Given this list of marker genes MFN2, NPAS2, VEGFD, GEM, CEP104, TOPBP1, MMD, MYL12B, DIXDC1, PGGT1B, PUM1, SNW1, CEP170, NR4A2, RBM19, ATF3 (activating transcription factor 3), SLC35B1, INPP5F, KCTD12, ZNF140, STXBP3, TGIF1, UBAC1, GNG5, PSG1, ACSL1, TNFSF11, ADGRE5, ZNF135, GOLGA8A, SLC31A1, RPS27A, IQCB1, NUP42 (nucleoporin 42), ATRX, AKAP1, IPO7, ADO, PLA2R1, PPT1, RP2, GABARAPL1, FABP5, IL23A, IER2, DDX52, RPS25 (NCBI Gene Id 6230), CENPE, WDHD1, ABCB7, TSC22D2, ADARB1, BTG3, ZEB2, TMEM268, SUSD6, RFTN1, STK25, ACSL4, NFKBIE, NFIA, VDAC3, IL1RL1, CAMTA2, PLP2, RRAGA, SRP9, DYRK3, PPP2R2B, PLAGL1, HLTF, EIF2S2, IFNGR1, GGPS1, SMAD7, NR3C1 (NCBI Gene Id 389335), AFF1, DUSP14, KHDC4, PKD2, DYRK2, GSTO1, DENND4B, MACF1, MPDZ, DMTF1, SRSF9, RGS16, GEMIN4, FUT4, AHR, RCN2, ZNF473, CCL20, MED13L, FMR1, GALNT1, GRK5, FICD, SLAMF1, MYD88, PRPF19, KLF10, HMGB1, GLT8D1, MED7, RPS16, MMP10, NDUFS4, EP400, NPEPPS (aminopeptidase puromycin sensitive), CD83, MAP3K8, ATG14, ZNF143, EED, RBPJ, FOXO1, ZNF292, DDX17, CTSL, EFNA1, YY1, RAB5A, SPARCL1 (SPARC like 1), OSER1, COL6A3, ZC3H13, MSL3, IFT27, CPNE3, PDGFA, UBE3A, BASP1, USP34, RFK, PTK2, BLMH, NEK4, UTP25, ACVR1, RPL17, CD58, TAF9, RBM25, ZNF165, ATP5PB, CSRNP2, CDK17, PLS3, UNC50, TES, ATP8A1, S100A11 (S100 calcium binding protein A11), TNFRSF9, HMGXB4, CPOX, CSNK1D, RPL37A, CYP51A1, SUGP2, RASGRP1, STK38L, IFIT3, OXA1L, CD6, EN2, SLK, ABCB1, HCP5, SPON1, HBEGF, JUN, SLC5A3, PDE1A, MAPKAPK5, RCHY1, SEPTIN2, SELENOF, RPL23AP53, REL, PPIL2, SPAST, ADGRG6 (adhesion G protein-coupled receptor G6), MTMR1 (myotubularin related protein 1), RANBP2, NINL, LCP2, TIAM1, RNASE2 (ribonuclease A family member 2), CCT6B, SLC16A4, MINPP1, CPD, H2AZ2 (NCBI Gene Id 94239), ZNF84, CDR2, RPP38, NDUFB6, here is a description of the gene set: species: Homo sapiens Genes up-regulated in CD4 T cells: progesterone versus TGFB1 and progesterone. from publication Lee JH, Ulrich B, Cho J, Park J, Kim CH (PMID 21768398) Human Gene Set: GSE22025_PROGESTERONE_VS_TGFB1_AND_PROGESTERONE_TREATED_CD4_TCELL_UP We examined the global gene expression pattern of T cells regulated by progesterone to gain further insights into the regulatory mechanisms of progesterone. We found 325-347 cord blood T cell genes up or down-regulated by P4 in the presence or absence of exogenous TGFb1. Peripheral blood T cells were relatively unresponsive with only 30-genes regulated by P4. IL-6 receptor (IL-6R) expression was greatly down-regulated by progesterone in cord blood, but not PB, T cells. Overall, these differences in gene expression are consistent with the differential responses of cord blood and peripheral blood T cells to progesterone. To gain insights into the differences of progesterone and control dendritic cells, we performed a microarray study and found ~genes regulated by progesterone in dendritic cells. The gene expression information suggests that progesterone has the potential to alter dendritic cell responses to cytokines, chemokine production, and migration which in combination would control T cell differentiation.